The following is a description of a gene set: Any process that stops, prevents or reduces the frequency, rate or extent of extrinsic apoptotic signaling pathway via death domain receptors. Human Gene Set: GOBP_NEGATIVE_REGULATION_OF_EXTRINSIC_APOPTOTIC_SIGNALING_PATHWAY_VIA_DEATH_DOMAIN_RECEPTORS species: Homo sapiens, and this is the list of marker genes: BCL2L1, RFFL, SFRP2, MIR222 (microRNA 222), ITPRIP, MIR221, FGA, BRCA1, HMGB2, SCRT2, FAIM2, DDX3X, GSK3B, RAF1, PEA15 (proliferation and apoptosis adaptor protein 15), TNFAIP3, RNF34, ICAM1, FGB, PARK7, BMP5, NOS3, GPX1, GRINA, TMBIM1, FGG, ARHGEF2, HMOX1, HGF, CFLAR, FAIM, SERPINE1